The following is a description of a gene set: Nlrp10-deficient mice have a profound defect in helper T cell-driven immune responses. T cell priming is impaired due to a defect in the emigration of a dendritic cells from inflamed tissue and antigen transport to draining lymph nodes. DC chemotaxis to CCR7-dependent and independent ligands is intact in the absence of Nlrp10. Therefore to identify novel molecules potentially involved in Nlrp10-dependent DC function we used an unbiased gene array approach on Nlrp10-deficient BMDCs treated with or without LPS. Human Gene Set: GSE36009_WT_VS_NLRP10_KO_DC_LPS_STIM_DN species: Homo sapiens Genes down-regulated in dendritic cells in response to LPS: wildtype versus NLRP10 knockout. from publication Eisenbarth SC, Williams A, Colegio OR, Meng H, Strowig T, Rongvaux A, Henao-Mejia J, Thaiss CA, Joly S, Gonzalez DG, Xu L, Zenewicz LA, Haberman AM, Elinav E, Kleinstein SH, Sutterwala FS, Flavell RA (PMID 22538615), and this is the list of marker genes: ADD3, CLK4, FOXK1 (forkhead box K1), COG3, NINJ1, DDX60, LPAR3, TNNI2, H2BC18, CCDC43, IPMK (NCBI Gene Id 253430), TOMM20L, RPL31, SRPX2, FAM114A1, TTC39B, CCDC125, GPR37, RPS6KB1, KPNA1, TNFAIP3, NUDT6, DSE, HNRNPA1, PHTF1, COPS2, MIEF1, MACO1, ENTPD5, FAM133B, SENP6, NDUFS1, SDHD, SMPD4, CEPT1, SFT2D3, BMAL1, HOXC8, TNKS2, PCNA, CDH26, MAN1A2, PGK2, CEBPZ, PI4K2B, CTDSPL2, LAP3, EXOC5, RPL13A, STRBP, ROCK2, SLC25A24, TDRD1, RBMXL1, MRPS18B, MBD2, RNF24, TTC3, ADH1C, REXO2, KBTBD2, CYP19A1, IWS1, OVGP1, RAB1A (RAB1A, member RAS oncogene family), OTULIN, TRAPPC10, VPS13D, PRKAR2A, FZD4, WBP4, TGFB3, PSMG2, EIF4A2, FAM76B (family with sequence similarity 76 member B), NOCT, LYAR, PDLIM1, PSME4, S1PR1, RAB4A, ZNF131, NEMF, PDE3A, KCNJ8, LMO1, HSPA9, CARD19, PCDHB14 (NCBI Gene Id 56122), ATAD1, BAZ1A, TWF1, ZKSCAN1, RAF1, CEND1, SLC35E2B, DNAJA1, CRBN, SETDB2, RBP7, F7, PTPRB, RPL13, CCT6A, PIP4K2A, PIBF1 (progesterone immunomodulatory binding factor 1), CSNK2A1, ABHD17B, CCNT2, RALA, BLTP2, MYO5A, ILF2, PNISR (NCBI Gene Id 84956), SNORD89, FAM78B, VIRMA, BORA, UFM1, INIP, WASHC2A, ENTPD4, CMTM2, GSK3B, BCAP29, BEND4, CHAC2, CALCRL, LTB4R2, STAG2, SNRK, ILKAP, TMEM183A, DDX28, LONRF1, MRPL3, ZKSCAN5, PLCG1, FGD3, SIK3, DOK7, NSMCE1-DT, SESTD1, CEP135, INTS7, TOR1B, CILK1, SNRNP48, GUCD1, NDUFAF4, ABCF2, ELAC2, TMC5, USP38, NRARP, NAE1, HNRNPA0, GPSM2, IREB2, GCSH, DDI2, PPM1H, ZNF703, ANGPTL1, POLDIP3, DENND1B, ZC2HC1A, TMEM38B, MAGOHB, NXF1, RMDN3, OTUD6B, TAPT1, POU3F3, CERT1, NIFK, PLEKHA2, HCST, FASTKD2 (FAST kinase domains 2), ARMC3, RNMT, SYCP1, FKBP14, SELENOT, FAM171B, LSS, ZBTB11, RRP15, ATP11C (ATPase phospholipid transporting 11C), EPC2, MYO9B, MDP1, ST13, WWTR1, WNT16, EVI2B, NSA2, STC2, ETFDH